Given this list of marker genes Ptk2b, Mapk3, Nsun4, Usp16, Ythdf3, Cnbp, Eif4a3l2, Thbs1, Pcif1, Uhmk1, Zcchc13, Rxra, Erbb2, Pcbp1, Hnrnpd, Mettl14 (methyltransferase 14, N6-adenosine-methyltransferase subunit), Rbm4, Pkm, Ythdf1, Dazl, Rcc1l, Abcf1, Eif5a2, Secisbp2, Rbms3, Ucn, Mrps27, Nat10, Pkp1, Otud6b, Bcl3, Rpl26, Jmjd4, Dhx36, Eif4a3, Pink1, Eef2, Barhl2, Slc35a4, Guf1, Tarbp2, Eif5a, Mir466l, Prkdc, Hnrnpu, Sox4, Mapk1, Eif3d, Ddx3x, Mtor, Pld1, Boll, Tent5b, Larp1, Mettl5, Ythdf2, Coa3, Eif2b5, Rps6kb2, Samd4, Rps27l, Upf3b, Uqcc2, Serp1, D1Pas1, Eif4g1, Rpusd4, Ogt, Pabpc1, Fxr1, Nck1, Ybx1, Krt17 (keratin 17), Larp4, Trmt10c, Mettl8, Pym1, Tnf, Poldip3, Piwil2, Fmr1, Plxnb2, C1qbp, Cdk5rap1, Syncrip, Rps6kb1, Sh3bgrl (NCBI Gene Id 68890), Niban1, Cdk4, Eif4a3l1, Rpusd3, Dhx29, Cyp1b1, Dhx9, Mettl3, Eif4g2, Ptafr, Il6, Ngrn, Ssb, Fastkd2, Trub2 (NCBI Gene Id 227682), Zcchc4, Ddx39b, Cirbp, Cpeb3, Nsun5, Habp4, Rpl5, Polr2g, Elavl1, Larp4b, Eif6, Csde1, Upf3a, Cpeb1, Eif2ak4, Smyd5, Fxr2, Rps4x, Dnajc3, Akt2, Paip1, Lin28a, Ep300, Eif3e, Prr16, Rmnd1, Rbm3, Ptbp1 (NCBI Gene Id 19205), Prkch (protein kinase C, eta), Igf2bp1, Fastkd3, Npm1, Eif4g3, Mpv17l2, Khdrbs1, Prmt1, Nck2, Itga2, Ago2, Akap6, here is a description of the gene set: Mouse Gene Set: GOBP_POSITIVE_REGULATION_OF_TRANSLATION Any process that activates or increases the frequency, rate or extent of the chemical reactions and pathways resulting in the formation of proteins by the translation of mRNA or circRNA. studied in species Mus musculus